Given this list of marker genes Tgfb2, Col5a1, Tmeff2, Nox1, S100a9, Ar, here is a description of the gene set: species: Mus musculus The chemical reactions and pathways resulting in the formation of integrins, a large family of transmembrane proteins that act as receptors for cell-adhesion molecules. Mouse Gene Set: GOBP_INTEGRIN_BIOSYNTHETIC_PROCESS